Given this list of marker genes Il4, Romo1, Prkcd, Cdkn1a, Cd177, Adcy10, Itgb2l, Agtr1a, Rab27a, App, Agt, Grin1 (NCBI Gene Id 14810), Duoxa1 (dual oxidase maturation factor 1), Pdgfb, Itgam, Tlr6, Itgb2, Tgfb1, F2rl1, Ogt (NCBI Gene Id 77137), Tlr4, Il18, Mapk14, Tyrobp, Zfp13, Cyp1b1, Mapt, Sod1, Foxo3, Gadd45a, Tgfbr2, Pid1, Cxcl1, Alox12, Sod2, Hdac4, Park7, Akr1c18, Rnf41 (NCBI Gene Id 75676), Nfe2l2 (nuclear factor, erythroid derived 2, like 2), Duoxa2, Cbr1b, Xdh, Grb2, Gstp1, Nox1, Cyba (cytochrome b-245, alpha polypeptide), Eif5a (NCBI Gene Id 28059), Ripk3, Snca, Lep, Elavl1, Clcn3, Nqo2, Slc5a3 (NCBI Gene Id 53881), Dcxr, Nox4, Crp, Cd36, Plcg2, Zc3h12a, Trp53, Plau, Lcn2, Adgrb1, Hvcn1, Nnt, Gnai3, Syk, Mfn2, Egfr, Ptk2b, F2, Acod1 (NCBI Gene Id 16365), Gnai2, Ager, Tspo, Fpr2, Cbr1, Clec7a, Pdgfrb, Thbs1, here is a description of the gene set: Mouse Gene Set: GOBP_POSITIVE_REGULATION_OF_REACTIVE_OXYGEN_SPECIES_METABOLIC_PROCESS species: Mus musculus Any process that activates or increases the frequency, rate or extent of reactive oxygen species metabolic process.